Given this list of marker genes SPTLC1, POU3F3, SIGMAR1, SLC39A14, GCDH, DNM1, PI4K2A, MCCC2, OPA1, DTYMK, DBT (NCBI Gene Id 1629), SLC19A3, FUS, TSEN2, GBA1, GLYCTK, PIGA, PANK2, CARS2, SPG11, VPS50, GALC, BCKDHB, NDE1, UGDH, PSAP, ALS2, NFU1, PTS, UFC1, TNR, GRIK2, KCNC2, SV2A, ALG11, MOCS2, SETBP1, CYB5R3, EXTL3, TOE1, AASS, NDUFA8, TSEN54, ASPA, MOCS1, TUFM, HPRT1, CLPB, PAFAH1B1, CRLF1, VPS53, ITPR1, GRIN1, PLCB4, KCNJ6 (potassium inwardly rectifying channel subfamily J member 6), ADSL, MCCC1, ASPM, here is a description of the gene set: Opisthotonus is defined as a dramatic abnormal posture due to spastic contraction of the extensor muscles of the neck, trunk, and lower extremities that produces a severe backward arching from neck to heel. In most cases, the trunk is elevated off the ground by a few inches. It is usually sudden in onset and can be sustained or repetitive. It can be considered a variant of decerebrate posturing involving a hyperextension of the neck, back, and limbs. Opisthotonus Human Gene Set: HP_OPISTHOTONUS studied in species Homo sapiens